The following is a description of a gene set: Transcriptional regulation by RUNX1 studied in species Homo sapiens Human Gene Set: REACTOME_TRANSCRIPTIONAL_REGULATION_BY_RUNX1, and this is the list of marker genes: PSMA7, SIN3B, KMT2C, TCF3, H4C9, RPS27A, PHC2, H4C3, CTSV, H2AC8, H2BC21, BMI1, CCNH, ARID1A, SPI1, H2AJ, OCLN, AGO2, H4C13, ITCH, CBX8 (NCBI Gene Id 63441), H2BC11, GATA2 (NCBI Gene Id 84724), H2BC12L, PSMD11, RYBP, TCF12, LIFR, H2BC26, TNRC6C, RUNX2, HDAC1, TP73, SEM1, H2BC9, EP300, SCMH1, PRMT1, CBX4, H2AC6, CSNK2A1, CTLA4, MYL9, ELF2, MOV10, LGALS3, ADRM1, ABL1, H2BC4, PCGF5, PSMB2, PSMA5, KMT2D (lysine methyltransferase 2D), H2BC5, PAX5, PSMB5, PF4, PRMT6, H4C2, TNRC6A, H4C4, H4C11, PSMA3, SETD1A (SET domain containing 1A, histone lysine methyltransferase), NR4A3, H2BC7, ACTL6B (NCBI Gene Id 51412), H3C15, CBX6, H4C1, UBC, CLDN5, H3C13, CBFB, NFE2, SERPINB13, PSMB3, H2BC8, MIR27A, PSMC6, ZFPM1, AGO4, H4C15, PSMD12, SMARCE1, CCND2, PSMD2, PBRM1 (NCBI Gene Id 55292), PSMD1, SMARCA2, UBB, PSMC3, TNFRSF18, IL2RA, H2BC3, PSMA1, H2AC14, CDK7, SMARCB1, KAT2B, CTSL, CSF2, SMARCA4, LMO2, WDR5, PSMD14, H2AZ2, LMO1, PSMD8, UBA52, PSMB1, TAL1, SMARCD1, H3C12, H2BC14, RING1, H3C14, H2AC20, PSMC2, H3C11, TJP1, AGO1, CSNK2B, PHC3, H2AC4, H3-3A, AXIN1, H2AC19, TNRC6B, KMT2A, PRKCQ, FOXP3, ARID2, SMARCD2, H2BC15, H4C5, MYB (NCBI Gene Id 4602), ACTL6A, KCTD6, RSPO3 (R-spondin 3), CBX2, H2BC6, H2BC1, RUNX1, ESR1, SOCS3, H3C3, H2AC7, PHC1, H2BC12, PSMC1, PML, H2AC18, PSMB6, ARID1B, DPY30, CR1 (complement C3b/C4b receptor 1 (Knops blood group)), CREBBP, H4C12, PSMB4, IFNG, AUTS2, PSMA2, SIN3A, CCND1, CSNK2A2, LDB1, PSMD13, PSMB7, YAF2, H3C7, H4C16, PTPN11, PSMC4, H3C4, H4C8, IL2, BLK (BLK proto-oncogene, Src family tyrosine kinase), THBS1, HIPK2, SRC, GATA1, H2BC10, PSMC5, IL3, H2AX, SMARCC1, MNAT1, AGO3, CDK6, H3C10, SMARCC2, CCND3, KMT2B, GP1BA, H3C6, GPAM, ITGA2B, H2BC17, SETD1B, SOCS4, PSMA6, ASH2L, PRKCB, H4C14, YAP1, H3C8, H2BC13, SMARCD3, RBBP5, H3C2, RNF2, ELF1, PSMA4, H2AB1, PSMD3, GATA3, H3C1, NFATC2, H3-3B, PSMD7, CTSK, H4C6, PSMD6